Given this list of marker genes Fut7, Fcer1g, Bdkrb2, Serpinb9, Fcgr1, Fcgr4, C3, Icam1, Npy, Spn, Nlrp6, Park7, Selenos, Fcgr3, Cxcr2, Ighg1, Il20rb, Gata3, Ephb6, Cd6, Fcer1a, Ccr7, Pla2g2d, Adcyap1, Npy5r, H2-T23, A2m, Ext1, Zp3, Elane, Cnr1, Ighe, Btk, Fcgr2b, Ighg2b, Il31ra, here is a description of the gene set: An acute inflammatory response to an antigenic stimulus. An acute inflammatory response occurs within a matter of minutes or hours, and either resolves within a few days or becomes a chronic inflammatory response. species: Mus musculus Mouse Gene Set: GOBP_ACUTE_INFLAMMATORY_RESPONSE_TO_ANTIGENIC_STIMULUS